The following is a description of a gene set: part of: TCF dependent signaling in response to WNT This event has been computationally inferred from an event that has been demonstrated in another species.<p>The inference is based on the homology mapping from PANTHER. Briefly, reactions for which all involved PhysicalEntities (in input, output and catalyst) have a mapped orthologue/paralogue (for complexes at least 75% of components must have a mapping) are inferred to the other species. species: Mus musculus electronically inferred by orthology from the curated human pathway Reactome Pathway: Formation of the beta-catenin:TCF transactivating complex, and this is the list of marker genes: Kmt2b, Ep300, Tcf7l1, Bcl9, Bcl9l, Men1, Tcf7, Pygo1, Pygo2, Tcf7l2, Ctnnb1, Tert, Leo1, Smarca4, Ash2l